Given this list of marker genes IGKV1D-13, AANAT, IGLL3P, PDE4A, MANF, DNAJC1, GSG1, METTL1, FICD, IL5RA, TOLLIP, HYI, OPTN, PINK1, CCR10, OR7E87P, HSD17B6, RCN1, KCNMB3, CAMK1G, PACS2, FBP1, CDCA3, MYO1D, FLT3, SLCO5A1, IGLJ3, TMEM177, WDR76, UCHL1 (NCBI Gene Id 7345), ZKSCAN1, CD320, IRF2BP1, FKBP2, CACNA1S, ZNF215, RAD54L, H2BC6, SEL1L, GTF3C5, TIMM17B, DARS2, SYNM, XCL1, NEU1, SCAMP2, KAZN, PKMYT1, ZNF91, PLAC1, TPX2, BLMH, CDKN1C, FKBP11, H4C4, CCNB2, GAB1, IGKV3-20, ZCCHC24, PIM2, GANAB, KIF20A, LIME1, LANCL2, CD160, CEP15, FAH, KIFC1, HPCAL4, PRDM1, CDK1, LAGE3, SMTN, IER3, SLC2A2, AGTR2, H3C11, RYBP, TIMP2, ANKRD26, EXO1, HESX1, WNT5B, MCHR1, G6PC3, ADGRE3, CARTPT, SMPDL3B, AQP3, ADA, GSTM1, UBE2C, GZMA (granzyme A), NENF, SEC14L1, CHPF2 (NCBI Gene Id 54480), PDK1, ASF1B, TMEM184B, CNKSR1, MMP15, RUNX1, SCN7A, KIF18B, RND1, MGAT1 (NCBI Gene Id 4245), SCRT1, ANKRD11, ECHDC3, AURKB, POLA2, CDC34, DNAH17, RNF208, EPHX2, CBX6, ARC, FAM149A, FER1L4, MEIS3P1, DHDDS, FOXF1, CIB2, PDE5A, TTC39A, GALR2, AXL, SARS2, TXNDC15, ARHGEF4, TSSK2, RRBP1, GJB3, BBOX1, IGKV1-5, SLC37A4, SPINK1, XRCC4, TIMM44, TRIB1, IL2, DHRS1, XBP1, BMS1P20, H2BC7, ARSA, SMPX, SHBG, PIR, DHRS9, LMAN1, PPIB, SEMA4A, DYNC1LI2, TK1, GADD45G (NCBI Gene Id 23575), GID4, GOT1, G0S2, IL15RA, ACTL7A, CTNNAL1, SPC25, DNAAF1 (dynein axonemal assembly factor 1), GCGR, ENSG00000291006, CCNF, CBARP, SMAD5-AS1, IGHM, NPBWR2, NR5A1, PYCR1, BTD, COPZ2, CLINT1, PMPCA, AFF2, IMPDH1, ALLC, CYP2E1, CACNA1F, MACO1, HSD17B3, H2AC14, PPP1R26, SERPINA2, RFX1, CDT1, GSTM3, RABEPK, GSTP1, AGPAT4, APOBEC2, SPICE1, BAK1, GPRC5D, SLC19A1, DGCR5, here is a description of the gene set: Genes down-regulated in comparison of naive B cells versus plasma cells. Human Gene Set: GSE13411_NAIVE_BCELL_VS_PLASMA_CELL_DN Enhanced secondary Ab responses are a vital component of adaptive immunity, yet little is understood about the intrinsic and extrinsic regulators of naive and memory B cells that results in differences in their responses to Ag. Microarray analysis, together with surface and intracellular phenotyping, revealed that memory B cells have increased expression of members of the TNF receptor, SLAM, B7 and Bcl2 families, as well as the TLR-related molecule CD180 (RP105). Accordingly, memory B cells exhibited enhanced survival, proliferation and Ig secretion, as well as entered division more rapidly than naïve B cells in response to both T-dependent and T-independent stimuli. Furthermore, both IgM and isotype switched memory B cells, but not naïve B cells, co-stimulated CD4+ T cells in vitro through a mechanism dependent on their constitutive expression of CD80 and CD86. This study demonstrates that upregulation of genes involved in activation, co-stimulation and survival provides memory B cells with a unique ability to produce enhanced immune responses and contributes to the maintenance of the memory B cell pool. from publication Good KL, Avery DT, Tangye SG (PMID 19124732) studied in species Homo sapiens